Given this list of marker genes RAD23B, SLX4, POLD1, XPA, ERCC4, CETN2, XPC, ERCC5, ERCC1 (ERCC excision repair 1, endonuclease non-catalytic subunit), ERCC3, XRCC1, ERCC8, here is a description of the gene set: species: Homo sapiens Human Gene Set: GOCC_NUCLEOTIDE_EXCISION_REPAIR_COMPLEX Any complex formed of proteins that act in nucleotide-excision repair.